Given this list of marker genes ADAM8, PLA2G5, SLC48A1, NCF1, LAMP1, MPEG1, NCF4, NCF2, here is a description of the gene set: A membrane-bounded intracellular vesicle formed by maturation of an early phagosome following the ingestion of particulate material by phagocytosis; during maturation, phagosomes acquire markers of late endosomes and lysosomes. Human Gene Set: GOCC_PHAGOLYSOSOME studied in species Homo sapiens